Given this list of marker genes CTTNBP2, SYNE1, NEDD9, DPYD, DLG2, TSHZ2, FER, MAGI2, AUTS2, NRG3, KCNT2, PAWR, BICC1, BCL2, ITGB8, PARD3B, RERG, ZEB1, AKT3, L3MBTL4, CCDC198, UTRN (utrophin), THRB, ACSM3, MBD5, PARD3, SLIT3, CCN2, CEP112, ZDHHC14, CFH, GULP1, MACF1, SPIDR, EDIL3, MACROD2, EXT1, AGBL4 (AGBL carboxypeptidase 4), MYO9A, KANK1, DST, ARHGAP29, GPHN, ZBTB20, GALNT14, BICD1, PALLD, MGAT4C, ZFPM2, SVIL, PDE1A, WWOX, BNC2, PDE7B, DCDC2, KLF6, TPM1, PRUNE2, MAML3, ALDH1A2, RBFOX1, SHROOM3, DANT2, RORA, RHEX, TMEM178B, EHBP1, ZBTB16, CNTN4, TTC28, TRAPPC9, FRMD4A, OSBPL10, NALF1, RBMS3, NR2F2-AS1, ARGLU1, CRIM1, PLEKHA7, TENM3, FBXL7, NOX4, CASC15, PLCB4, LINC01435, ENTREP2, here is a description of the gene set: Human Gene Set: LAKE_ADULT_KIDNEY_C29_UNKNOWN_NOVEL_PT_CFH_POS_SUBPOPULATION_S2 studied in species Homo sapiens from publication Lake BB, Chen S, Hoshi M, Plongthongkum N, Salamon D, Knoten A, Vijayan A, Venkatesh R, Kim EH, Gao D, Gaut J, Zhang K, Jain S (PMID 31249312)